Given this list of marker genes CDKN2A, NUSAP1, ANKRD24, ACTA1, CFH, SUGT1 (SGT1 homolog, MIS12 kinetochore complex assembly cochaperone), RSPO2, HYCC2, MST1R, PDZK1, EDC4, AOX1, ABCD2, CELA1, SLC1A3, RPP21, PCDH15, DACH1, WASHC4, ATF7IP2, AQP4, PNOC, CRK, GRIA4, FKBP2, SERINC1, SSNA1, THSD1, ACSL6, RHOBTB2, C8G, RPF1, TIMM50, RPL37A, ANKRD46, COQ8B, GMPPA, HHAT, CLDN3, TRMT2A, P2RY12, ARHGAP5, ACRV1, ZBTB16, CCNT1, SUOX, EIF1AY, RPL41, SMAD9, MECR, POLE3, CFAP68, DERA, CTLA4, FAM43A, RHBDL1, RMND1, RPTN (repetin), PRIM2, SRPX2, STAT5A, COPS5, GTSF1L, MYO5B, ZBTB48, HEMK1, PIP5K1B, CDC123, MSTO1, CACNB4, PIKFYVE, MTURN, NTSR1, HAS1, DGUOK, RTP3, PTRHD1, POU3F4, CUEDC2, FXR1, CLDN1, IFI27L2, DNPH1, TXLNB, ACADSB, SFRP1, KERA, N4BP3, SPRYD4, POLR3F, NDUFB10, PEX2, LAMTOR4, KCNA2, TCF4, SPMIP10, PRDX3, DENND1B, FAIM, CDKN2AIPNL, TM9SF4, RPLP0, MYL10, ARL2, PLVAP, PFDN5, RPS5, BRCC3 (BRCA1/BRCA2-containing complex subunit 3), PCDHB13 (protocadherin beta 13), PCBP3, TMCO6, PSENEN, RBM4B, GBP6, TUSC3, BST2, HOXB1, DNAJA4, CHMP1B (charged multivesicular body protein 1B), ORMDL3, DGCR8, FUT8 (NCBI Gene Id 2530), GPRC5B, NRBP1, FCAMR, ZNF654, HSD11B1, RPS14, THUMPD1, SNRPB2, SLAMF9, HOMER1, SULT1B1, MTCH2, RPL11, IGF2BP2, CNOT8, CABP7, CALHM5, BRMS1, MDH1, MIS18BP1, KRT1, FBLN1, C11orf58, ZNF207, PPP2R3C, OSTF1, ABAT, USP3, COX14, TMEM258, CPTP, ERLIN1, FBXL15, MFSD4B, CRABP1, GOLM1, DMXL1, C5orf24, PLK1, YJU2B, AKAP3, SNX10, MRPL4, LEPROT, B3GALNT2, PDZRN3, CHGB, RPS25, AIMP2, SNRPD2, IL9R, YIPF5, LYSMD3, MAP1LC3B (NCBI Gene Id 81631), RAMP2, NT5C3A, EIF3M, OVOL2, PPP1CA, UBE2S, HEATR6, CDC26, CPN1, PITPNB, PSMB1, SDHAF2, ZNRD2, USP17L2, PSMF1, ZNF276, MYCT1, ZNF35, NAA15, RDH5, TRIM15, SCML2, PTRH2, BACE1, here is a description of the gene set: mouse primary BMDCs were stimulated with tlr ligands and gene expression changes were profiled on Affymetrix arrays Human Gene Set: GSE17721_PAM3CSK4_VS_CPG_0.5H_BMDC_DN from publication Amit I, Garber M, Chevrier N, Leite AP, Donner Y, Eisenhaure T, Guttman M, Grenier JK, Li W, Zuk O, Schubert LA, Birditt B, Shay T, Goren A, Zhang X, Smith Z, Deering R, McDonald RC, Cabili M, Bernstein BE, Rinn JL, Meissner A, Root DE, Hacohen N, Regev A (PMID 19729616) species: Homo sapiens Genes down-regulated in comparison of dendritic cells (DC) stimulated with Pam3Csk4 (TLR1/2 agonist) at 0.5 h versus DC cells stimulated with CpG DNA (TLR9 agonist) at 0.5 h.